The following is a description of a gene set: Spherophakia is a rare congenital condition that presents with weak zonules around a more spherical crystalline lens with an increased anteroposterior thickness of the lens, and highly myopic eye. The lens zonules are developmentally hypoplastic and abnormally weak and due to non-attachment of the posterior zonules to the equatorial zone of the lens, the lens changes its normal shape to spherical. Human Gene Set: HP_SPHEROPHAKIA species: Homo sapiens Spherophakia, and this is the list of marker genes: ASPH, LTBP2, ADAMTS10, FOXC1, PAX6, RRAGC, TRIM44, FBN1, ADAMTS17